The following is a description of a gene set: Human Gene Set: GOBP_VENTRICULAR_CARDIAC_MUSCLE_CELL_DEVELOPMENT species: Homo sapiens The process whose specific outcome is the progression of a ventricular cardiac muscle cell over time, from its formation to the mature state. Cardiac muscle cells are striated muscle cells that are responsible for heart contraction. The ventricle is the part of the heart that pumps blood out of the organ., and this is the list of marker genes: NKX2-5, CCNB1, MYH10, HEY2, PITX2, FHL2, CDK1, MEF2A, ATG5, LMNA, BMP10, PROX1, NKX2-6